The following is a description of a gene set: from publication Napolitani G, Rinaldi A, Bertoni F, Sallusto F, Lanzavecchia A (PMID 15995707) Genes down-regulated in comparison of unstimulated dendritic cells (DC) at 0 h versus DCs stimulated with LPS (TLR4 agonist) and R848 for 2 h. Human Gene Set: GSE2706_UNSTIM_VS_2H_LPS_AND_R848_DC_DN studied in species Homo sapiens Toll like receptors (TLRs) sense microbial products and initiate adaptive immune responses by activating dendritic cells (DCs). Since pathogens may contain several agonists we asked whether different TLRs may synergize in DC activation. We report that in human and mouse DC TLR3 or TLR4 potently synergize with TLR7, TLR8 or TLR9 in the induction of selected cytokine genes. Upon synergistic stimulation, IL-12, IL-23 and Delta-4 are induced at levels 50-100 fold higher than those induced by optimal concentrations of single agonists, leading to enhanced and sustained TH1 polarizing capacity. Using microarray analysis we show that only 1.5% of the transcripts induced by single TLR agonists are synergistically regulated by combinations of TLR4 and TLR8 agonists. These results identify a combinatorial code by which DCs discriminate pathogens and provide (suggest) a rationale to design adjuvants for TH1 responses. Series_overall_design: 3 untreated, 3 treated with LPS at 2h, 3 treated with LPS at 8h, 3 treated with R848 at 2h, 3 treated with R848 at 8h, 3 treated with LPS + R848 at 2h, 3 treated with LPS + R848 at 8h, and this is the list of marker genes: IL10RA, CXCL1, IFIT3 (interferon induced protein with tetratricopeptide repeats 3), TCF7L2, BID, ETV3, USP12, INSIG1, SNHG15, NR4A2, EZH2, NFKBIA, RAB3IP, TRAF1, SAR1A, NEMP1, TNFAIP3, BTG3, CILP2, LAMP3, LRRC32, TMEM268, IFIH1, RETREG1, MBL2, ADA, CCRL2, SERPINA12, EDN1, OXT, BTG2, SLAMF7, TTYH2, IFIT1, MIR155HG, DAPP1, ICAM1, CXCL9, PTGS2, RILPL2, GBP1, ZIC2, SOCS3, DCUN1D3 (defective in cullin neddylation 1 domain containing 3), ERN1, IRF8, MARCKSL1, IFNB1 (NCBI Gene Id 3456), IL1A, PXDC1, AFAP1L2, DRAM1, ITGB8, ISG20, IFI44, ZNFX1 (zinc finger NFX1-type containing 1), IL15RA, BATF, EHD1, DUSP2, RGS1, ZNF697, NR4A3, RTP4, IL15, HES4, C15orf48, RELB, IL36G, STAT4, DNAAF1, ZC3H12C, CLDN1, GEM, REL, NCF1C (NCBI Gene Id 654817, neutrophil cytosolic factor 1C (pseudogene)), PML, CXCL3, PLEKHA3, ARL5B, PTGER4, OASL, RIPK2, CD274, IL6, ZBTB43, PIM3, TRIP10, ZC3H12A, BATF2, CFLAR, LYRM1, VCAN, DDX3Y, BIRC3, MT1E, HIVEP1, MIR3945HG, MFSD2A, CYTOR, KLF7, GPR132, C12orf54, GRASLND, RSAD2, FSD1L, CYRIA, CXCL10, CREB5, ST7-AS1, IL18RAP, TLR8-AS1, APOBEC3A, TNIP2, ATF3, HERC6, NABP1, CXCL11, MAP3K8, PPP1R15A, DNAJB4, CHST7, GALNT3, IRF1, C2orf15, RASSF5, JUNB, ISG15, LINC03025, LTA, GPR183, PRODHLP, PLAUR, SIAH2, CMPK2, NFKBIZ (NFKB inhibitor zeta), BTG1, CFB, GADD45A, CSRNP1, P2RX7, RAPGEF2, BAZ1A, TP53BP2, STX11, NETO2, TNFAIP8, IRF7, NAMPT, C17orf58, SCARNA17, MASTL, RAB30, NUP98, ANKRD33B (NCBI Gene Id 651746), TNFRSF4, MIR3142HG, ACSL1, DUSP1, SELENOK, PELI1, TNFAIP2, CCR7, MIR9-1HG, SRF, IFIT2, FXYD6, RASGRP1, SLC1A2, SLAMF1, HCAR3, CDKN1A, TPPP, HS3ST3B1, NFKB1, SAMD9, DUSP5, KCNA3, ENSG00000284634, RNF144B, PLK3, TMEM39A, TTN, ZC3HAV1, TNIP1, RAB21, CXCL2, ARAP2, KCNJ2, LAMA3, TUBB2A, LDLR